The following is a description of a gene set: species: Homo sapiens Human Gene Set: GOBP_CELL_CELL_ADHESION_INVOLVED_IN_GASTRULATION The attachment of one cell to another cell affecting gastrulation., and this is the list of marker genes: MAPK7, IL10, MIR221, IL1RN, KLF4, RIC8A, ADIPOQ, MYADM, MAP2K5, WNK1, APOA1, MBP